The following is a description of a gene set: Any process that affects the structure and integrity of a protein, altering the likelihood of its degradation or aggregation. Mouse Gene Set: GOBP_REGULATION_OF_PROTEIN_STABILITY studied in species Mus musculus, and this is the list of marker genes: Tsc1, Vps35, Hspd1, Usp17lc, Cdk7, Pin1, Gnl3l, Abtb3, Cdc37l1, Atp1b2, Lamp2, Ufl1, Sav1, Ddost, Pdcl3, Tbx3, Tcp1, Mtrr (5-methyltetrahydrofolate-homocysteine methyltransferase reductase), Trim6, Usp25, Zbed3, Cdkn2aip, Gtpbp4 (NCBI Gene Id 85330), Sec16a, Pyurf, Nf2, Cct2, Gpihbp1, Lamp1, Pim2, Trim21, Dpm2, Wdr81, Frey1, Tnip2, Tmem88, Stk3, Dsg1b, Ubl4a, Ppib, Morc3, Bbof1, Tardbp, Rassf2, Trp53, Ahsp, Rnf139, Trim39, Dnlz, Rpl23, Htt, Usp9y, Pten, Fbxo7, Tyrobp, Usp34, Tspan1, Fbxl3, Igf1, Snca, Bmp2, Flot2, Stxbp1, Npm1, Cmtm6, Asgr2, Usp13, Usp36, Bag1, Rnf128, Crebbp, Flna, Glmp, Usp17lb, Bag2, Chfr, Ctnnd1, Cct8, Kcnu1, Lss, Sugt1, Cul3, Usp28, Ncln, Usp4, Nedd4l, H1f5, Tesc, Srebf1, Usp29, Ifi30, Pdcd10, Usp38, Marchf7 (membrane associated ring-CH-type finger 7), Usp46, Lrrk2, Tescl, Park7, Pycard, Derl1, Apoa1, Csn3, Naa16, Plpp3, Clec16a, Trim24, Coa8, Nop53, Prkdc, Zfp207, Dcaf11, Dsc3, Hip1, Usp19, Tpr, Bag4, Calr, B4galt5, Usp40, Gnaq, Gm715, Ubr4, Saxo1, Hip1r, Lyset, Efna1, Cct3, Mdm2, Irgm2, Wfs1, Rab3gap1, Aak1, Zswim7, Dact1, Mtmr9, Usp18, Otud3, Ccar2, Dvl1, Brinp1, Ywhaz, Atp1b3, Ccnh, Siah3, Pik3r1 (NCBI Gene Id 328326), Kdf1, Siah1a, Serf1, Nckap1, Gapdhrt, Cog7, Caml, Usp47, Usp35, Mul1, Tmem25, Chp1, Xbp1, Dsg3, Bag6, Pex2, Rpl5 (ribosomal protein L5), Slc51b, Commd1, Tcf3, Trex1, Usp17le, Golga7, Negr1, Hcfc1, Casp3, Cd74, Usp37, Cct5, Tada2a, Swsap1, Ncor2, Prkn, Dubr, Serf2, Igtp, Usp33, Tbrg1, Tmc6, Stk4, Utp25, Cct4, Wiz, Stub1, Clu, Get1, Taf9 (NCBI Gene Id 72718), Phb1, Sppl2c, Mapk8ip3, Nr1d1, Syvn1, Capn3 (calpain 3), Hsp90ab1, Ctsa, Aurka (NCBI Gene Id 99385), Ncor1, Smo, Aptx, Pex19, Pink1, Kat2a, Sox17, Usp12, A1cf, Get4 (NCBI Gene Id 67604), Usp42, Rpl11, Pml, Usp8, Naa30, Ipo9, Gipc1, Ddi1, Src, Adgrv1, Pfn1, Cep63, Tmc8, Apbb2, Sirt1, Usp1, Ddrgk1, Ip6k2, Hsp90aa1, Septin8, Usp30, Creb1, Cdkn2a, Dad1, Hdac8, Flot1, Cryab, Irgm1, Senp2 (NCBI Gene Id 75826), Pfn2, Lmna, Usp27x (ubiquitin specific peptidase 27, X chromosome), Ift46, Usp2, Mcm8, Smad3, Atp1b1, Rps7, Rad23a, Apoa2 (NCBI Gene Id 11807), Telo2 (NCBI Gene Id 71718), Prkra, Stxbp4, Isoc2b, Gapdh, Pin1rt1, Tert, Smad7, Iapp, Prnp, Rnf149, Rtn4, Hdac6, Dvl3, Trim37, Nlk, Hdac3, Fbxw7, Asph, Atf7ip, Wnt10b, Rab21, Ddi2, Cenpe, Tada3, Cdc37, Mapk1, Cog3, Ccdc88c, Dsg1c, Usp48, Bcl2, Sumo1, Pim1, Per3, Siah1b, Bag3 (BCL2-associated athanogene 3), Usp7, Mt3, Gapdhrt2, Sirt6, Msx1, Stx12, Usp17la, Chek2 (checkpoint kinase 2), Usp10, Mtor, Pex6, Gga3, Naa15, P3h1, Dazap2, Cct7, Afm, Phb2, Pinx1, Isoc2a, Tomm7, Id1, Usp26, Ndc80, Bag5, Dsg1a, Nlrp5, Hspa8, Ctsh, Hspa1b, Apbb1, Paqr4, Rabl3 (NCBI Gene Id 67657), Usp24, Rnf5, Hypk, Ep300, Fbxo4 (NCBI Gene Id 67521), Ift80, Hps4, Ptges3, Usp9x, Cdc73, D7Ertd443e, Epha4, Taf9b, Crtap, Fam107a, Ube2b, Kdm8, Gsn, Dpm3, Cryaa, Fbxw11, Cblc, Btrc, Akt2, Rassf1, Cct6a, Ptges3-ps, Grn, Mfsd1, Otud5, Cd81, Crebl2, Sox4, Ank2, Plk1, Insc, Mfsd8, Mylip, Dnaja3 (NCBI Gene Id 98023), Trim44, Tbl1x, Qrsl1, Mosmo, Usp5, Ubr5, Usp17ld